Given this list of marker genes Man1a, Mgat1, Manea, Man1c1, here is a description of the gene set: electronically inferred by orthology from the curated human pathway Reactome Pathway: N-glycan trimming and elongation in the cis-Golgi part of: Transport to the Golgi and subsequent modification This event has been computationally inferred from an event that has been demonstrated in another species.<p>The inference is based on the homology mapping from PANTHER. Briefly, reactions for which all involved PhysicalEntities (in input, output and catalyst) have a mapped orthologue/paralogue (for complexes at least 75% of components must have a mapping) are inferred to the other species. studied in species Mus musculus